Given this list of marker genes CHD4, ICAM4, MTX2, SLC11A1, DUSP2, KCNN4, EIF2B4, here is a description of the gene set: species: Homo sapiens Childhood acute lymphoblastic leukemia (ALL) is curable with chemotherapy in approximately 80 percent of patients. However, the cause of treatment failure in the remaining 20 percent of patients is largely unknown. Genes distinguishing daunorubicin resistant and sensitive ALL (B- and T-lineage ALL); here - genes up-regulated in the drug resistant samples. from publication Holleman A, Cheok MH, den Boer ML, Yang W, Veerman AJ, Kazemier KM, Pei D, Cheng C, Pui CH, Relling MV, Janka-Schaub GE, Pieters R, Evans WE (PMID 15295046) Human Gene Set: HOLLEMAN_DAUNORUBICIN_ALL_UP